The following is a description of a gene set: species: Homo sapiens Human Gene Set: REACTOME_PI_3K_CASCADE_FGFR2 PI-3K cascade:FGFR2, and this is the list of marker genes: GAB1, FGF23, FGFR2, FGF7, GRB2, FGF16, FGF5, PTPN11, FGF18, FGF20, FGF2, FGF1, PIK3R1, FGF3, FGF10, FGF9, PIK3CA, FGF22, FGF6, FRS2, FGF17, FGF8, FGF4